Given this list of marker genes CSNK2A2, KLC1, KIF5B, PRNP, CSNK2B, KLC3, KIF5C, CSNK2A3, GSK3B (NCBI Gene Id 2932), KLC2, KLC4, CSNK2A1, KIF5A, here is a description of the gene set: Pathway Definition from KEGG: PRNP* -> (GSK3B,CK2) -| (KIF5+KLC) Oligomeric conformation PrPc to anterograde axonal transport. Pathway ID: N01202. Pathway type: Variant. Pathway class: nt06465 Prion disease. Human Gene Set: KEGG_MEDICUS_VARIANT_OLIGOMERIC_CONFORMATION_PRPC_TO_ANTEROGRADE_AXONAL_TRANSPORT studied in species Homo sapiens